Given this list of marker genes EXT1 (NCBI Gene Id 3966), AXIN2, GATA5, RBPJ, WNT5A, BMP2, POU5F1, BMP4, SMARCD3, MEF2C, FOXH1, ROBO2, DKK1, MESP1, ISL1, WNT11, ROBO1, LRP2, here is a description of the gene set: species: Homo sapiens Human Gene Set: GOBP_HEART_FIELD_SPECIFICATION The process that results in the delineation of a specific region of the lateral mesoderm into the area in which the heart will develop.